Given this list of marker genes SOX4, SRA1, TGFB1, TBX3, SOSTDC1, BMP4, SOX9, IL18, DLL1, DDIT3, TMEM182, NMRK2, NOTCH1, ANKRD2, ID3, PPARD, MSTN (myostatin), EID2B, CXCL10, GDF3, TNF, CMTM5, SOX8, MBNL3, PRICKLE1, ZFHX3, CSRP3, here is a description of the gene set: Human Gene Set: GOBP_NEGATIVE_REGULATION_OF_MYOBLAST_DIFFERENTIATION studied in species Homo sapiens Any process that stops, prevents, or reduces the frequency, rate or extent of myoblast differentiation. A myoblast is a mononucleate cell type that, by fusion with other myoblasts, gives rise to the myotubes that eventually develop into skeletal muscle fibers.